The following is a description of a gene set: Any process that activates or increases the frequency, rate or extent of leukocyte apoptotic process. Mouse Gene Set: GOBP_POSITIVE_REGULATION_OF_LEUKOCYTE_APOPTOTIC_PROCESS species: Mus musculus, and this is the list of marker genes: Ido1, Cdkn2a, Pdcd1, Anxa1, Bbc3, Cd24a, Perp, Pdcd7, Bcl2l11 (NCBI Gene Id 76339), Lyn, Prelid1, Wnt5a, Trp53, Zc3h8, Jak3, Pik3cb, Hcar2, Il10, Cd274, Nf1 (neurofibromin 1), Siglec1, Tgfb2, P2rx7, Bax, Adam8, Ccl5, Cd47, Cd44 (NCBI Gene Id 99339), Nfkbid, Pik3cd, Nr4a3, Rapgef2, Mef2c, Fnip1, Myc (NCBI Gene Id 17869), Sirt1